The following is a description of a gene set: Human Gene Set: HP_HYPERSOMNIA Excessive sleepiness or feeling of sleepiness, or difficulty staying awake despite having had adequate sleep, which persists over several days. studied in species Homo sapiens Hypersomnia, and this is the list of marker genes: TDP2 (tyrosyl-DNA phosphodiesterase 2), MOG, AIP, GPR101, DUOX2, PAX8, PRNP, PRR12, TRANK1, TSHR, FOXE1, NKX2-5, HCRT, NKX2-1, DNMT1 (NCBI Gene Id 1786), PTRHD1, SLC26A4, HEXB